Given this list of marker genes ADH1A, SDR16C5, RDH5, ALDH1A1, FABP5, CRABP1, ADH1C, CRABP2, ALDH8A1, RXRA, DHRS4, RARG, RXRB, DHRS3, PPARD, RDH13, RDH10, RARB, ALDH1A3, PDHX, ADH4, CYP26A1, PDK1, PDHA2, RDH16, PDK4, DLAT, PDK2, PDHA1 (NCBI Gene Id 5160), DLD, DHRS9, RDH11, CYP26B1, ALDH1A2, RDH14, PDHB, PDK3, RXRG, CYP26C1, AKR1C3, RARA, here is a description of the gene set: Human Gene Set: REACTOME_SIGNALING_BY_RETINOIC_ACID Signaling by Retinoic Acid studied in species Homo sapiens